The following is a description of a gene set: The attachment of a neuron to another cell via adhesion molecules. Human Gene Set: GOBP_NEURON_CELL_CELL_ADHESION studied in species Homo sapiens, and this is the list of marker genes: NRXN3, RET, NCAM2, NLGN4Y (NCBI Gene Id 375846), NLGN3, TNR, NLGN2, ASTN2, NRXN2, NRXN1, NLGN1, CNTN4, NLGN4X, CDK5R1, NINJ2, ASTN1